The following is a description of a gene set: species: Homo sapiens The regulated exocytosis of secretory granules containing preformed mediators such as perforin and granzymes by a natural killer cell. Human Gene Set: GOBP_NATURAL_KILLER_CELL_DEGRANULATION, and this is the list of marker genes: NKG7, KLRF2, HLA-F, AP1G1, CD160, VAMP2, UNC13D, LAMP1, CORO1A, VAMP7, RAB27A, KLRC2, FCGR3A